Given this list of marker genes COL6A2, COL9A3, COL11A2, COL6A1, COL23A1, MMP9, ADAM10, COL18A1, MMP10, MMP20, PHYKPL, COL1A2, MMP14, COL3A1, COL4A3, COL12A1, COL8A2, COL9A1, COL26A1, COL17A1, MMP3, COL10A1, MMP1, PRSS2, COL4A2 (NCBI Gene Id 1284), COL8A1, ADAM9, COL6A3, MMP7, COL16A1, COL9A2, COL11A1, COL2A1, COL25A1, CTSD, ELANE, COL19A1, CTSL, MMP8, COL5A3, COL1A1, CTSK, COL15A1, COL13A1, COL4A1, COL4A6, CTSB, MMP15, MMP13, MMP19, FURIN, COL4A4, TMPRSS6, COL6A5 (collagen type VI alpha 5 chain), COL5A2, COL7A1, COL5A1, MMP2, MMP11, MMP12, COL4A5, ADAM17, COL6A6, COL14A1, here is a description of the gene set: studied in species Homo sapiens Collagen degradation Human Gene Set: REACTOME_COLLAGEN_DEGRADATION